The following is a description of a gene set: A ribonucleoprotein complex found in the cytoplasm of male germ cells, composed of exceedingly thin filaments that are consolidated into a compact mass or into dense strands of varying thickness that branch to form an irregular network. Contains mRNAs, miRNAs, and protein components involved in miRNA processing (such as Argonaute proteins and the endonuclease Dicer) and in RNA decay (such as the decapping enzyme DCP1a and GW182). species: Mus musculus Mouse Gene Set: GOCC_CHROMATOID_BODY, and this is the list of marker genes: Piwil2, Piwil1, Ddx25, Ddx4 (NCBI Gene Id 13206), Ddx6, Tdrd1, Eif4e, Nsun2, Tdrd6, Slc25a54 (solute carrier family 25, member 54), Bmal1, Ago2, Mael, Smg1, Marcks, Tdrd7, Clock, Tdrd5